The following is a description of a gene set: studied in species Homo sapiens from publication Chen Y, Wang X (PMID 31504780) Human Gene Set: MIR9500 Genes predicted to be targets of miRBase v22 microRNA hsa-miR-9500 in miRDB v6.0 with MirTarget v4 prediction scores > 80 (high confidence targets)., and this is the list of marker genes: UCP2, FOXD4L6, ELFN2, RANBP10, PIANP, PCK2, ATAT1, LALBA, CTNND1 (NCBI Gene Id 82168), SETD4 (SET domain containing 4), CCNT1, AP3B1, SPICE1, PKIB, STOX2, FAM168A, TACR1, GPR176, UNC119B, SLC22A23, HOOK3, ZNF354C, MGST2, UBE2A, HLA-C, FREM2, LRRC59 (leucine rich repeat containing 59), BAZ2A, PBX1, GTPBP3, DPH6, SMARCD1, PPM1N, CTAGE1, ADO, POGZ, MTMR11, PIK3CG, MID2, NUP160, MAGI1, PRKCA, CCDC186, GSK3B, RPRD1B, TIMP3, SPRR2G, PLCD4, AHSA2P, DNAJB4, ZNF572, WDR77, KSR2, LIN28A, POU2F1, SMAD2, RD3, SNX27, ENTPD7, MED13L, ZCCHC4, PKD2, ZNF106, PAX6, HNRNPC, GRAMD1B, DENND4B, MAFG, TPI1, XPNPEP1, FBXL14, VPS45, RIMOC1, FBXO42 (NCBI Gene Id 54455), NECTIN1, LRRC41, HOPX, FOXD4L3, SEMA4C, KCNMA1, PHACTR2, TNRC6B, ATF7IP, USP10, PLEKHH2, SDC1, GALNT13, LSAMP, FBXO11, C20orf96, MMP28, HLA-B, BICRAL, CMKLR1, GJB1, GDAP2, POM121, BOLA3 (bolA family member 3), PGAP2, ANKS6, HYLS1, PRDM10, GSPT1, UHMK1, FOS, CDK5R2, PTPRE, RAB3B, PIK3C2B, NRIP3, GLIS3, THSD7A, MIA3, EDDM3B, OAS2, ST8SIA2, VPS39, PABIR1, MEX3A, DMBX1, PAK2, ROCK2, VAMP1, TMEM183A, UBE2L3, PHOX2A, IP6K2, SLC25A15, CYP17A1, ESYT1, PTPRJ, FNDC5, CYP4A22, HAPSTR2, PITPNC1, TNNI1, SST, HYCC2, ANAPC5, TFAP2A, PAK6, HERC3, KDM7A, IL6R, NEXMIF, SYT2, TMOD2, F2RL2, NFAT5, CCDC43, EPB41L2, SP1 (Sp1 transcription factor), STEAP3, HMGXB4, ZMPSTE24, C2orf49, CMTR1, CHD6, LILRA4, SPMIP4